The following is a description of a gene set: studied in species Homo sapiens from publication Chen Y, Wang X (PMID 31504780) Human Gene Set: MIR5588_5P Genes predicted to be targets of miRBase v22 microRNA hsa-miR-5588-5p in miRDB v6.0 with MirTarget v4 prediction scores > 80 (high confidence targets)., and this is the list of marker genes: CSNK1G1, DNAJC24, PLXNA2, OSTF1, CREBRF, BACH2, KRT32, FOXJ3, TNP1, PPP1R9B, FBXO33, ARMC1, GTF2E1, ALPK3, COL13A1, SC5D, FAM171A1, CDX2, AGAP1, PLXDC2, EBAG9, AFDN, LRIG3, XAGE1B, DPY19L2, PLPPR1, SDK2, ERICH3, BTBD1, BRWD3, BTBD7, PPFIBP1, RIOK3, NRXN1, STARD13, RAB3C, DLEU7, NKAIN2, JMJD1C, ABRAXAS2, NBEA, DKK2, ACKR3, STIMATE-MUSTN1, GPAT3, ZNF512B, MAP2, TAFA3, MGAM, ISX, HYCC2, MUSTN1, RER1, SF3B1, SV2C, UBE2G1, YY1, KRT74, BNIP1, TLR2 (NCBI Gene Id 7097), VANGL1, SHOC2, MRGBP, PIK3R1, STOX2, WRNIP1, CHST15, GTSF1, N4BP2L1, L3HYPDH, ARHGEF38, NF1, EGLN1, CDC26 (NCBI Gene Id 246184), SLC38A2, USP16, LEPROTL1, MYBL1, COBLL1, PDE6A, ANP32E, GCNT2, WASL, GAN, REST, SND1, SLC25A4, LSM8, PHACTR2, BCORL1